Given this list of marker genes Arl8a, Kif1a, Fez1, Kif1b, Dync1h1, Agbl4, Ap3b1, Kif5b, Mecp2, Hsbp1, Trak1, Dst, Bloc1s4, Sod1, Rab27b, Kif1c, Actr10, Dtnbp1, Rab21, Fbxw11, Armcx3, Sybu, Bloc1s1, Mapk8ip3, Spg7, Spast, Ap3m1, Kif5c, Ap3s2, Ndel1, Pafah1b1, Ap3m2, Map2, Bloc1s6, Atg5 (autophagy related 5), Trim46, Hif1a, Bloc1s2, Tmem230, Tmem108, Ap3b2, Hdac6, Kif5a (NCBI Gene Id 52905), Arl8b, Ap3s1, Hap1, Cnih2, Kif21a, Bsn, Caly, Hspb1, Madd, Map1a, Bloc1s5, Uchl1, Mgarp, Snapin, Terf2, Map6 (NCBI Gene Id 17760), Agtpbp1, Nefl, Ank3 (NCBI Gene Id 73013), Dlg2, Ap3d1, Bloc1s3, Kif3a (NCBI Gene Id 192824), Atg16l1, Borcs5, Neto1, here is a description of the gene set: Mouse Gene Set: GOBP_AXONAL_TRANSPORT The directed movement of organelles or molecules along microtubules in axons. studied in species Mus musculus